Given this list of marker genes CDK13, ZNF335, CDK5RAP2, TCF4, ASPM, CENPJ, KIF14, MCPH1, here is a description of the gene set: Small cerebral cortex Human Gene Set: HP_SMALL_CEREBRAL_CORTEX Reduced size of the cerebral cortex. species: Homo sapiens